The following is a description of a gene set: studied in species Homo sapiens Human Gene Set: GOBP_INTRACILIARY_TRANSPORT_INVOLVED_IN_CILIUM_ASSEMBLY The bidirectional movement of large protein complexes along microtubules within a cilium that contributes to cilium assembly., and this is the list of marker genes: IFT81, DYNC2LI1, CEP131, SSX2IP, IFT74, IFT56, PCM1